Given this list of marker genes AP1G1, CLINT1, CLTC, EPN1, SLC18A3, NECAP2, EPN2, EPN3, AP1M1, SGIP1, AFTPH, AP1B1, AP1M2, AP1S3, EPS15, MYCBPAP, NECAP1, AP2S1, AP2B1, CLBA1 (clathrin binding box of aftiphilin containing 1), CLTB, ENTHD1, AP2M1, NCALD, AP1S1, AP1S2, AP1G2, CLTCL1, TBC1D5, BTBD8 (NCBI Gene Id 284697), STON2, CLTA, SYNRG, AP2A1, STON1, AP2A2, here is a description of the gene set: A clathrin coat found on a vesicle. Human Gene Set: GOCC_CLATHRIN_VESICLE_COAT species: Homo sapiens